The following is a description of a gene set: Human Gene Set: GOBP_LYMPHOCYTE_CHEMOTAXIS studied in species Homo sapiens The directed movement of a lymphocyte in response to an external stimulus., and this is the list of marker genes: CCL4, PADI2, CXCL16, CXCL12, ADAM8, CXCL10, CCL2, CCL21, GPR15LG, STK39, PTK2B, CYP7B1, GPR183, PIK3CG, MSMP, HSD3B7, DEFA4, GAS6, NEDD9, ADAM17, PIK3CD, ADAM10, CCL5, PLEC, TMEM102, CH25H, S100A7, CCL26, DEFA1, CCL7, SLC8B1, CCL3, TNFSF14, SLC12A2, SAA1, CXCR3, WNK1, CXCL13, KLRK1, WNT5A, CKLF, XCL1, CXCL11, DEFA1B, CX3CL1, OXSR1, CCR2, KLRC4-KLRK1